Given this list of marker genes Doc2b, Syt9, Trim9, Syt3, Rims1, Rph3a, Cplx1, Syt11, Cplx4, Cplane2, Syt5, Znrf2 (zinc and ring finger 2), Rims2, C2cd5 (C2 calcium-dependent domain containing 5), Stxbp1, Doc2g, Slamf1 (NCBI Gene Id 27218), Syt4, Coro1a, Syt2, Doc2a, Ankrd27, Grik5, Pla2g4a, Cplx2, Syt13, Prrt2, Znrf1, Snca, Kif5b, Syt7, Vamp1, Cplx3, Tbc1d4, Erc2 (NCBI Gene Id 52497), Rimbp2, Erc1, Anxa1, Sphk1, Rph3al, Cacna1b, Syt1, Anxa2, Rab3a, Syt8, here is a description of the gene set: Mouse Gene Set: GOBP_REGULATION_OF_VESICLE_FUSION species: Mus musculus Any process that modulates the frequency, rate or extent of vesicle fusion.